Given this list of marker genes VDR, SBDS, CYP27B1, CYP2R1, SLC34A3, DNAJC21, EFL1, here is a description of the gene set: Deformed rib cage studied in species Homo sapiens Human Gene Set: HP_DEFORMED_RIB_CAGE Malformation of the rib cage.